Given this list of marker genes Ddr1, Vtn, Plau (NCBI Gene Id 18792), Apod, Efemp2, Pcsk5, Serpine1 (serine (or cysteine) peptidase inhibitor, clade E, member 1), here is a description of the gene set: species: Mus musculus Mouse Gene Set: GOBP_SMOOTH_MUSCLE_CELL_MATRIX_ADHESION The binding of a smooth muscle cell to the extracellular matrix via adhesion molecules.